Given this list of marker genes FBXL7, NAV3, CA12, TMEM183A, FTMT, NFXL1, RNF11, SHPK, AQP2, CENPH, DHFR, LBX1, ARMH4, DGCR8, CDCA5, AGMAT, IL17RE, RNF182, WIPI2, SMPD4, HAT1, OGDH, USP32, ZNF410, MYO1C, CNIH4, IGFBPL1, TENT4A, CHRNB4, STRADB, ZNF184, SPIDR, MVK, NECTIN3, SCNN1A, AXDND1, FAM170B (NCBI Gene Id 399567), GAS7, NRG3, STRN3, LRRC74A, ZNF711, WIPI1, TRIM69, VCAN, CFAP69, PGAP4, DMWD, SEBOX, UBFD1, DNM1, AKAP7, SPATA17, HOXC6, DOC2B, RGCC, AHSG, VSNL1, SGK3, RNF39, CLDN3, NME3, UROC1, ASB6, ST3GAL2, RFWD3, PLPPR3, ARRDC4, PRKAA2, CEP128, RHBDF1, ARRB1, DNAL1, NID1, NKX1-2, E2F2, IRS2, HOXA3, CRYGS, LRRK2, ADORA3, AQP9, SLC16A11, PRL (NCBI Gene Id 5617), TSHR, MPP3, MPZL2, HSPA4L, OLFML3, MINDY1, HTR2B, SIRT6, PALB2, FBXW4, GARIN1B, GALNT15, JHY, MFAP4, CHIA, ASAH2, UBXN2A, PAX6, FBLN1, CHRD, MRPL49, TMOD2, RPUSD1, TIMM50, ID1, CELA2A, KPNA2, KIF27, H2BC5, PWWP2B (NCBI Gene Id 170394), RSAD2, CXCL14, SMCO2, SERTAD3, BORA, FAM169A, KIZ, XK, SMC1B, SMARCA5, LGI3, WDR7, PRC1, ARL6IP6, LMLN, PDZD11, NUP93, HS6ST1, FZD10, HTR1B, USP21, IL20, WDR27, DNAJB4, NXPH3, MAP4K5, RIMS4, GPR158, SIK2, CCDC90B, GPR182 (G protein-coupled receptor 182), PKD2L2, RNF19A, KRTAP3-1, DCAF10, TCEAL9, SLC25A42, GET4, COQ4, FIRRM, SMAD6, KCND2, SYNDIG1L, MFSD4B, FUT2, PHYHIP, CXXC5, PEX5L, TNFRSF10A, MEMO1, G6PC2 (NCBI Gene Id 57818), CHST11, IL13RA1, MYEF2, IPP, ANKRD54, AGBL5, TSKU, KCNB1 (potassium voltage-gated channel subfamily B member 1), AJM1, SGSM3, DIRAS1, OOEP, PFKM, KBTBD7, FANCD2OS, ARHGEF12, C19orf33, KIF23, TLX1, GMEB2, SEMA4G, UPP2, ALLC, WDR55, ATG2A, ERBB4, TNS2, LRRN2, COL6A3, DLG5, BRD3OS (NCBI Gene Id 266655), TRAPPC6B, TBCCD1, PPM1D, ASPDH, here is a description of the gene set: Genes down-regulated in comparison of CD4 T cells versus erythroblasts. from publication Konuma T, Nakamura S, Miyagi S, Negishi M, Chiba T, Oguro H, Yuan J, Mochizuki-Kashio M, Ichikawa H, Miyoshi H, Vidal M, Iwama A (PMID 21540074) studied in species Homo sapiens Human Gene Set: GSE27786_CD4_TCELL_VS_ERYTHTROBLAST_DN Each fraction of mouse hematopoietic cells was purified by cell sorting from bone marrow of 8-week-old C57BL/6 mice, and its gene expression was analyzed.